Given this list of marker genes Gclc, Ttll2, Asns (NCBI Gene Id 27053), Ttll1, Ppcs, Mthfd1, Ttll7, Mthfsl, Ass1, Ghdc, Ttll3, Ttll4, Pfas, Ttll5, Gmps, Fpgs, Cps1, Asnsd1, Ttll11, Ttl, Ttll8, Adss2, Gart, Gss, Ctps2, Gatc, Ttll9, Nadsyn1, Hlcs (holocarboxylase synthetase (biotin- [propriony-Coenzyme A-carboxylase (ATP-hydrolysing)] ligase)), Qrsl1, Adss1, Rimkla, Ttll6, Naprt, Ttll10, Dph6, Gclm, Lgsn, Paics, Mthfs, Glul, Ctps1, Ttll12, Carns1, Ttll13, Rimklb, Cad, Mthfd1l, Tpgs1, Gatb, here is a description of the gene set: Mouse Gene Set: GOMF_LIGASE_ACTIVITY_FORMING_CARBON_NITROGEN_BONDS studied in species Mus musculus Catalysis of the joining of two molecules, or two groups within a single molecule, via a carbon-nitrogen bond, with the concomitant hydrolysis of the diphosphate bond in ATP or a similar triphosphate.